The following is a description of a gene set: Human Gene Set: GSE3982_NEUTROPHIL_VS_EFF_MEMORY_CD4_TCELL_UP In the present study we used Affymetrix oligonucleotide microarrays to produce gene transcription profiles for the major leukocyte types in humans. This comprehensive dataset enabled us to not only establish which genes were expressed in each leukocyte type, but also which genes were expressed in each subset after activation. The used of a comprehensive dataset of gene profiles from all the major human leukocyte subsets enabled a novel and powerful means for identification of genes associated with single leukocyte subsets, or different immune paradigms. Genes up-regulated in comparison of neutrophils versus effector memory CD4 T cells. species: Homo sapiens from publication Jeffrey KL, Brummer T, Rolph MS, Liu SM, Callejas NA, Grumont RJ, Gillieron C, Mackay F, Grey S, Camps M, Rommel C, Gerondakis SD, Mackay CR (PMID 16474395), and this is the list of marker genes: POR, TCIRG1, PAK2, KLHL2, NRDC, MTMR6, MXD1, SLC6A6 (NCBI Gene Id 6533), RBCK1, DAPP1, ADGRG3, CYB5R1, MARCKS, SLC25A44, MARCHF5 (membrane associated ring-CH-type finger 5), TECPR2, APOBEC3A, USP9X, PACSIN2, SLC12A6, PI3, ARAP3, FCGR1A (NCBI Gene Id 50698), NINJ2, TM6SF1, SLCO3A1, CYP4F2, UBE2J1, TSG101, ITGAX, LIMK2, NTRK1, ERP44, RRAGD, RRP12, FCAR, LRRFIP1, PELI1 (pellino E3 ubiquitin protein ligase 1), TLE3, SMARCD3, ZYX, CEBPA, UPF1, FAM53C, GNG5, RALB (NCBI Gene Id 5899, RAS like proto-oncogene B), NQO2, FOSL2, TMEM59, P2RY14, ELF2, CAPZA2, FAM89B, SRSF5 (NCBI Gene Id 6430), PRR14, DYSF, PADI4, DBN1, ZNF394, GBP1, COTL1, ATP5F1E, DAPK2, PYCARD, CDA, CALML4, HSPBAP1, FRMD4A, ADGRE2, ZDHHC18 (NCBI Gene Id 84243), NDEL1, DNAJB12, SNORA21, ZNF200, YIPF1, TST, ORAI3, TRIM38, DENND5A, DOCK4, SECTM1, CYTH4, FMO1, RARA, TRPC4AP, XKR8, BRCA1, RAB32, SIRPA, TNFRSF10C, DENND3, MAP2K4, MKLN1, PLK3, GPSM3, HEXIM1 (NCBI Gene Id 10614), VNN3P, LMO2, HEY1, ISG15, ZNF516, MAFG, BCL3, SAMD9, RAP2C, BAZ1A, OSM, CHD1, VWA7, GSK3B (glycogen synthase kinase 3 beta), PHC2, APOBR, PRCP, RAF1, TLR6, LST1, RHBDF2, RCOR3, SLC22A1, MTTP, CDK12 (NCBI Gene Id 51755), PFKFB3, CLTB, GNAQ, RRAGC, RAB7A, TNFRSF1A, ZFP36L1, PSTPIP2, FOXO3, RUBCNL, JUNB, OSTF1, ITGBL1, STX10, CERS2, ZNF267, IMPDH1, AP3S1, EVI2A, MCL1, MICU1, ZCCHC2, ALOX5, PPP1CB, BCL6, CAP1, PLSCR1, CCDC87, PSENEN, GALNS, CSK, ICAM3, NCOA1, MYO9B, TSGA10, IRF9, SPATA6L, DGAT1, MAPK1, TMCC1, CYTIP, XPO6, NEAT1, NFYA, FTL, HLA-A, HAUS4, GLB1L, PPP1R15A, ACP3, MED16, LINC00472, EXT1, CANT1, IFNGR1, BMP2K, NLRP3, SDCBP, ATP6V0C, SERPINA3, SERINC3, OSBPL8, POLB, PTPRE, MPPE1, SH2B2, SEMA6A, BTN2A2, IRF1, PRKD2, MTNR1A, NAB1, BLTP3B, CEACAM3, SORT1, SMIM27, SULT1B1, GIT2